The following is a description of a gene set: Human Gene Set: HP_MACULAR_COLOBOMA A congenital defect of the macula distinct from coloboma associated with optic fissure closure defects. Macular coloboma is characterized by a sharply defined, rather large defect in the central area of the fundus that is oval or round, and coarsely pigmented. studied in species Homo sapiens Macular coloboma, and this is the list of marker genes: PRPS1, NMNAT1, RPE65, DHX38, TENM3, MMACHC, CLDN19, CRB1 (crumbs cell polarity complex component 1), LRAT, LCA5, SPATA7